Given this list of marker genes SLC25A38, HAMP, SLC40A1, FTH1, TFR2, HJV, BMP6, STEAP3, PIGA, PKLR, HFE (homeostatic iron regulator), here is a description of the gene set: studied in species Homo sapiens Elevated transferrin saturation An above normal level of saturation of serum transferrin with iron. Human Gene Set: HP_ELEVATED_TRANSFERRIN_SATURATION